The following is a description of a gene set: studied in species Homo sapiens Nicotine effect on dopaminergic neurons Human Gene Set: WP_NICOTINE_EFFECT_ON_DOPAMINERGIC_NEURONS, and this is the list of marker genes: PPP1R1B, KCNK9, KCNK3, CHRNA4, CHRNB2, PRKACA, PPP1CA, GNG2, DDC, DRD2, GNAI1, DRD4, GNB1, SLC18A2, CDK5, CHRNA3, DRD3, ADCY2, CHRNA6, TH, CHRNA5